The following is a description of a gene set: Mouse Gene Set: GOBP_NEGATIVE_REGULATION_OF_FATTY_ACID_METABOLIC_PROCESS Any process that stops, prevents, or reduces the frequency, rate or extent of the chemical reactions and pathways involving fatty acids. species: Mus musculus, and this is the list of marker genes: Sox9, Dbi (NCBI Gene Id 13167), Acacb, Apoc3, Trib3, Ceacam2, Klhl25, Erlin2, Pibf1, Acadvl, Erlin1, Insig2, Cnr1, Acadl, Dgat2, Ins2, Apoc1, Fmo1, Ncor1, Appl2, Wdtc1, Ceacam1, Plin5, Ubr4, Mir214, Akt1, Etfbkmt, Cyp7a1, Insig1 (insulin induced gene 1), Fmo2, Mir199a-2, Slc22a13 (solute carrier family 22 (organic cation transporter), member 13), Sirt1, Mfsd2a, Sirt4, Dcaf5, Fmo4, Ins1, Brca1